Given this list of marker genes RAB11FIP1, COPS7A, NAGLU, BRD8, AZIN1, ATAD5 (ATPase family AAA domain containing 5), FASTKD5, PNKD, SLC22A14, HAP1, CENPK, ZEB2, ALOX15B, BRCA2, POLD2, CACYBP (calcyclin binding protein), EME1, ZC3HC1, PRMT7, MEIOC, NDUFB9, DDX18, RPA1, SYT1, DHX29, OR51B2, NMI, NUP85, PRKCSH, LONRF3, NUDT21, SLC35B4, U2SURP, UTP18, TMEM209, MZB1, SPATA6L, ASB9, ZCRB1, LYAR, CDK2, SMS, NTN1, PFDN2, MRPS10, DDX39A, DCUN1D2, GFOD1, KIFC1, OIP5, ERICH2, FOXRED1, NUP43, CD200, GNB1L, CLRN3, CHAF1B, B3GALT6, CCT6A, DUT, WDR76, SLC7A5, CCND2, PTPN18, GTF2H2, CHCHD3, IRAK2, PIGK, BUB1B, CENPJ (centromere protein J), ERI2, NR4A1, SRGAP2, IFIH1, SMARCB1, MCM10 (NCBI Gene Id 55388), MAN1C1, TRIM17, PPIH, MORN2, TM4SF5, IFITM2, ORC1, ZNF239, ESPL1, CNIH4, NF1, WDR62, LRRC20, SOX6, C17orf75, FH, PSMG1, GPR183, SWI5, MKRN2, RUVBL1, SRSF7, HAT1, IQSEC1, ETV5, C19orf44, COL9A3, TRIP13, H1-10, KIF11, ALKBH7, SPINT1, CLPB, MCU, NDUFA7, NRSN1, LAP3, SPATA7, SPI1, SPAG5, TFAP2C, PCDHAC1, TIMM8B, ADORA2A, DNA2, WDR31 (WD repeat domain 31), FOXRED2, MTFP1, DLD, ASAP1, BSND (NCBI Gene Id 7809), DCAF17 (DDB1 and CUL4 associated factor 17), VILL (NCBI Gene Id 50853), NUP93, ZNF426, MEMO1, LSM4, ATP5F1E, MSH2, PSMA7, NUSAP1 (nucleolar and spindle associated protein 1), ENY2, DACT3, MRPL39, ZP2, IL1RAP, GTPBP4, AARS1, B3GNT6, FANCB, CASQ1, NRF1, RWDD1, AURKAIP1, IQCA1, MN1 (MN1 proto-oncogene, transcriptional regulator), SSR2, RFC1, ETFA, C4orf46, CENPE (NCBI Gene Id 1062), APLF, NPM3, GNAI1, JAZF1, ZC3H15, HINT1, AMFR, RBBP8, PASK, MDC1 (mediator of DNA damage checkpoint 1), AKIP1, TBC1D7, MRPS11, PSMB3, TECPR2, UQCR10, PHKA2, KPTN, FIRRM, ADI1, PRIM2, HEXA, CRLS1, NDUFA9, DNAAF2, LITAF, CYB5R1, CEP152, EPHB4, PARP2, SCIN, TECR, NMT1, CST7, ANAPC5, CD274, MLF1, DHFR, SPDL1, RCN2, EGR1, NUP37, here is a description of the gene set: species: Homo sapiens Human Gene Set: GSE8921_UNSTIM_0H_VS_TLR1_2_STIM_MONOCYTE_12H_UP In innate immune responses, activation of Toll-like receptors (TLRs) triggers direct antimicrobial activity against intracellular bacteria, which in murine, but not human, monocytes and macrophages is mediated principally by nitric oxide. We report here that TLR activation of human macrophages up-regulated expression of the vitamin D receptor and the vitamin D-1-hydroxylase genes, leading to induction of the antimicrobial peptide cathelicidin and killing of intracellular Mycobacterium tuberculosis. We also observed that sera from African-American individuals, known to have increased susceptibility to tuberculosis, had low 25-hydroxyvitamin D and were inefficient in supporting cathelicidin messenger RNA induction. These data support a link between TLRs and vitamin D-mediated innate immunity and suggest that differences in ability of human populations to produce vitamin D may contribute to susceptibility to microbial infection. Genes up-regulated in monocytes: untreated versus M. tuberculosis 19 kDa lipopeptide (12h). from publication Liu PT, Stenger S, Li H, Wenzel L, Tan BH, Krutzik SR, Ochoa MT, Schauber J, Wu K, Meinken C, Kamen DL, Wagner M, Bals R, Steinmeyer A, Zügel U, Gallo RL, Eisenberg D, Hewison M, Hollis BW, Adams JS, Bloom BR, Modlin RL (PMID 16497887)